The following is a description of a gene set: Human Gene Set: GOBP_REGULATION_OF_CATABOLIC_PROCESS studied in species Homo sapiens Any process that modulates the frequency, rate, or extent of the chemical reactions and pathways resulting in the breakdown of substances., and this is the list of marker genes: STYX, ABCA2, USP7, ERCC4, ATP6V0D2 (ATPase H+ transporting V0 subunit d2), TAF9, WDR45, IDH1, ATXN3, MIR9-1, SIRT2, EP300 (E1A binding protein p300), CDK5R1, SLC11A1, RAD23B, APOC1, BTG2, LRIG2, TIRAP, SYNCRIP, RIPK2, PAFAH1B2, NRBP2, CIRBP, PLK2, LZTS1, HTRA2, TRIM32, CASC3, TOB1, WNK1, XIST, RPL11, CSNK2B, ARNT, VCP, MEX3D (mex-3 RNA binding family member D), PHAX, TAF1, MIR181B1, TMEM39A, TRIM67, ASB9, MIR365A, DELE1, GBA1, SCFD1, MALAT1, PIK3CB, SH3RF3, ATP6V1C2, MIR100, DXO, ATP6V0A1, HIPK2 (homeodomain interacting protein kinase 2), MAD2L2, UBE2A, MIR373, DRAM1, CREBRF, DNM3OS, DFFB, NRDE2, IFNB1, MIR140, MIR625 (microRNA 625), ATP6V0A2, CACNG7, IER3, MIR655, CDC37, SMARCC1, IRS1 (insulin receptor substrate 1), UCHL5, MTCH2, TNF, TRDMT1 (tRNA aspartic acid methyltransferase 1), AKT2, CARHSP1, RHBDD3 (rhomboid domain containing 3), USP13, GCK, CAPRIN1, FASTKD1, IL10, EIF6, TNRC6A, USP38, PPP2CA, FOXO3 (forkhead box O3), MIR20A, PDE12, PIP4K2B, TRIM27, ADAM9, MIR145, ROCK2, TIMP4, ADRA1A, SESN3, PPTC7, BCL2L1, KCNE2, DHRSX, CDC20, FBXL5, TFEB, MIRLET7C, DISC1, POLR2G, MIR200C, ZFP36L2, MIR27A, METTL1, CCNY, CUL4B, FASTKD3, MIR106B, APOC2, MIR137, ZFP36L1 (NCBI Gene Id 677), CDH1, NPC1 (NPC intracellular cholesterol transporter 1), UVRAG, TECPR1, RNH1, DAB2IP, KEAP1, SNX7, VPS26B, MDM2, RRAGD, MIR199A1, SCARB2, CLSTN3, CSNK2A1, LRPPRC, ENDOG, LAPTM5, PRKAG2, MAPK8, FBXL4, SF3B3 (NCBI Gene Id 9661), PFKFB1, RPL23, LSM1, USP33, INS, CISD2, SRSF1, MIR30B, RBX1, ACACB, NEAT1, TPCN1, ZMPSTE24, FOXK2, BSCL2, CDC20B, DHX9, LARP4B, MIR98, ATP6V1A, ATXN3L, SOX17, EGF, STK38L, SCT, PRXL2C, PML, ACER2, APOA2, LAPTM4B, MET, UBE3A, METTL16, RAB26, SH3GLB1, PKD1, PABIR1, SH3RF1, PRKCE, HERPUD1, ATG12, CAMKK2, UBB, RBM10, MTM1, NPRL2, SCOC, N4BP1, ENPP7, SEC22B, EGLN1 (NCBI Gene Id 54703), UBQLN2, PATL1, HDAC4, PIK3CG, HPGD, PPP1R3B, GPD1, PSME3, CNOT3, OGT, NLRP6, AGTPBP1, ATP6V1H, CNOT2, MFSD2A, OAZ1, DFFA, DAZ2, VPS29, TRIB2, KAT2B, ODC1, ABHD5 (abhydrolase domain containing 5, lysophosphatidic acid acyltransferase), MIR608, GAPDH, TIMP3, MIR96, HNRNPA0, IFNG, SH3D19, RUFY4, ELOB, SMAD3, PSMD3, SIRT1, MIR29B1, RBM33 (RNA binding motif protein 33), ARID5A, MIR125A, MAP1A, PIK3R2, MUL1, DDIT4, FUT1, MIR519D, DCAF12, HDAC6, TMEM9, TTC5, GRIN2A, MIR191, TRIM39, HMOX1, ELAVL1, USP9X, AZIN1, P2RX7, EIF4A3, CNOT4, GRIN2C, USP20, NKD2, VPS13D, TSPAN5, CAMLG, DDX49, PPP1R3D, LARP1, RNF180, HSPB1, BMF, PHKA1, FXR1, SMCR8, MIR564, PTPN1 (protein tyrosine phosphatase non-receptor type 1), PAN3 (NCBI Gene Id 376186), APP, MEFV, TRAF3IP2, MIRLET7B, MTOR, GDNF, ALDOB, PLEKHN1, PTK2B, MLH1, MYCBP2, MIR130A, PSEN1, UBQLN1, CDK2, MIR326, MIR517A, MIR18A, HCAR1, HIF1A, CNOT8, PDCL3, FZR1, PIK3C3, LRRK2, RBM38, CPT1A, WIPI1, RNF5, ZAR1, PHF23, PRKCD, HSPBP1, GNAI3, MFSD8 (major facilitator superfamily domain containing 8), MIR211, HSP90AB1, MIR34B, CSNK2A3, MIR423, PKP3, PATL2, RNASEL, SNX18, MYD88, A1CF, ATRAID, ATP6V1E1, MIR21, BAG5, EEF1A2, CSNK2A2, DCN, TRAF5, FOXF2 (forkhead box F2), GPX1, PSMD2, CSDC2, APOA5, TAB2, SNF8, RNF139, IDE, NBAS, TRIM65, ZCCHC17, ABCD2 (ATP binding cassette subfamily D member 2), CHEK2, ULK3, GSK3A, HERC1, ADORA1, CSNK1D (casein kinase 1 delta), IKBKG, PDE3B, HSP90AA1, PSME1, SERPINB12, ATP6V1B1, FBLL1, MIR210, TP53, TENT4B, TARDBP, METTL14, TIMP1, PRMT6, DAPL1, MIR342, LEP, TP53INP1, MIR103B1, TPCN2, TRIM71, MIR19B1, AXIN1, PLK3, MIR491, GIT1, CDK5, USP30 (ubiquitin specific peptidase 30), PHKG2, PARL, LRP1, MIR206, RC3H2, PSMC4, IGF2BP3, GPR137B, DHX36, ZC3HAV1, IRAK3, TICAM1, SLC2A6, EGFR (epidermal growth factor receptor), VHL, C9orf72, MCL1, EXOC4, SLC7A5, CAPN1, VIM, MT3, MIR495, ELAVL4, EIF4G2, ALK, F8A3, QRICH2, PYHIN1, FYN, CRYBA1, TENT5D, WASHC1, DTL, FLNA, MIR26B, MIR142, VIP, MSN, LRP2, SETD2, TNKS1BP1, FYCO1, LACRT, ANGEL2, RELA, HNRNPC, AADAC, UBE2K, YBX3, RCHY1, ZFAND2A, PAQR3, RMC1, PABPN1L, KHSRP, DACT1, ATG101, MIR203A, MIRLET7A1, KAT5, PIK3CA, DDA1, L3MBTL3, GPR137, PITHD1, PACSIN3, ATP6V0E1, MIR4286, NUB1, NEURL3, TSPAN17, DAB2, MIR320A, XPO1, IL33, GFAP, MIR190B, ZER1, APC, MARCHF2, HSF1, BBS7, DEPDC5, TMX1, SOCS5, DRAM2, LATS1, PSMD10, PIP4K2C, TRIM40, YTHDF1 (YTH N6-methyladenosine RNA binding protein F1), CHFR, CST3, RAB37, AGO3, RAB3GAP2, PNPLA2, CPEB3, AGBL4, TSC1, RAD23A, TGFB1I1, ZYG11B, UBXN1, KDM4A, ARL2, TNFSF12, EHMT2, HTR2A, WNT5A, STING1, HOTTIP, CLEC16A, MIR199B, PIK3R4, SHH, ASB5, MIR27B, MAPKAPK2, MIR20B, METTL3, FASTK, F8A1, PIAS4, TENT4A, CISD1, PLK1, MIR23A, HNRNPD, AQP11, TLK2, MIR93, AGO4, CAV3, STX5, APAF1, BCL2, ZDHHC19, RHEB, ITCH, ADRA2A, PSMC3, MIR562, EIF4G1, EGLN2 (NCBI Gene Id 54750), PTPN3, EEF1A1, RPTOR, PANO1, NDUFA13, NANOS2, XBP1, PIK3C2A, BNIP3L, SREBF2, TLR9, ZC3H18, USP36, FBXO2 (NCBI Gene Id 4930), DAPK3, TRIM8, RNFT2 (NCBI Gene Id 84900), SLIRP, NSF, GIGYF2, FHIT, NOCT, WDR6, RNF152, MAD2L1 (mitotic arrest deficient 2 like 1), MIR195, SNX12, DCAF1, PRKAA1, MAGEA3, CNOT6, TIGAR, AMBRA1, RNF185, WDR91 (NCBI Gene Id 29062), TREX1, DAZL, IRGM, E2F1, FKBP8 (NCBI Gene Id 23770), GAPDHS, IL4, VPS13C, INSR, PTK2, TMEM168, EZR, PHB1, PPP2R3A, RAB8A, MIR497, SOCS4, GPC3, GPLD1, NICOL1, PCSK9, NANOS1, CNOT6L, SCGB1A1, ZC3H12A, PHF20L1, BCAP31, EIF2AK1, PRR5L, ZBTB7A, ATP6V1B2, ANGPTL3, SGTA, CYP51A1 (NCBI Gene Id 1595), DEPTOR, TRIM21, MIR337, PIN1, HNRNPAB, DET1, RAB7A, RIDA, TUT4, SNX3, MIR544A, SAMD4A, COP1, HNRNPU, BTRC, IRGQ, PCBP4, PABPC1, PAIP1, USP5 (ubiquitin specific peptidase 5), SMAD7, SMAD4, ABCB11, TMTC3, SAMD4B, LRSAM1, EPM2A, TBRG4, NT5C3B, WDR41, TF (transferrin), ATP6V1C1, GGA3, DAP, CNOT11, CEBPA, FURIN, USP19, EXOC8, HUWE1, DCP1B, HSPB8, MIR181D, DTX3L, TENT2, MAPT, CSNK1E, PIM2, MIR19A, MIR517C, RPS7, ABL1, DAOA, NOD1, CAPNS1, TMEM59, MGAT3, PIWIL2, MIR665, NUDT15, ZC3H12D, RBM46, SPTLC2, MIR302C, DNM1L, CSDE1, SPTLC1, TRIB3, VSIR, TENT5B, FAF1, SLC4A1, SUFU (SUFU negative regulator of hedgehog signaling), DDIT3, UBXN2A, ELAPOR1, MAP2K1, ULK2, CBLB, IGF2BP2, DAPK2, HAX1, MTMR2, MIR212, YTHDF2, CDK16, PKP1, VPS35, GATA5, CUL3, TUT7, ANXA2, GTSF1, NOP53, FUS, RBM8A, FOXO1 (forkhead box O1), ZKSCAN3, MIR663A, HGF, DAGLB, MIR329-1, DIS3, EIF3H, YTHDF3, MIR128-1, DESI1, FXR2, MYLIP, GIPC1, UBQLN4, ARAF, KAT8, TRIM13, NCOR1, CNOT7, ATG5, RIC1, BAG6, SERPINE2, EIF4ENIF1, SERBP1, SUMO2, ATP6V0B, MAGEA6, NOD2, MIR520C, PRKAA2, MAGOH, RARRES2, FEZ1, PAN2, CELF1, PLIN5, APOE, CHMP6, ZNF418, RHBDD1, VPS26A, MIR483, YBX1, ATP6V1G1, NQO1, MIR302A, MIR106A, SNX33, FTO, MIR223, ARHGAP5-AS1, ATP6V1G2, FBXL2, ATP6V0C (ATPase H+ transporting V0 subunit c), NPRL3, DAZ1, PPARA, MIR135B, EIF4E, FAM76B, MIR149, UPF3A, PRKACA, ATG16L1, PSAP, OAZ3, LEPR, CALCOCO2, TSC2, TOM1, BARD1, HMGB1, VPS28, ABL2, IGF1, PNPT1, USP8, IRS2, ACTN3, DIS3L2, UPF1, MIR204, RILP, OSBPL7 (NCBI Gene Id 54871), AXIN2, UFL1, MOAP1, MTCL2, UCHL1, SH3BP4, MAP3K7, MAPK9, SREBF1, PSMC2, GABARAP, FOXK1, ROCK1, MIR214, MIR200B (NCBI Gene Id 406984), CNOT9, NPM1, FMR1, MIR181A2, APEX1, RPGR, PRKAG1 (protein kinase AMP-activated non-catalytic subunit gamma 1), DCP2 (decapping mRNA 2), SNX32, PABPC4, TIPARP, TWIST1, RNF41, MIR185, CCDC22, MIR708, FBXW7, SESN1, MIR181C, ATP6V0E2, ZBTB20, NSUN2, HAMP, DEPP1, PRICKLE1, FAP, MAPK14, ADCY10, ZNF268, CASP3, HFE, PSMF1, MIR192, SNX4, TOMM7, USP14, IREB2 (iron responsive element binding protein 2), BECN1, RRAGC, TRAF2, MAGOHB, TREM2, GCLC, STUB1, PSME3IP1, HSPA1B, FLCN, SUPV3L1, TRIB1, DNAJB2, PARN, USP26, SNCA, PSMD14, MDM4 (NCBI Gene Id 4194), DVL1, EIF4G3, PTPN22, UBQLN3, TIMP2, TBC1D25, ADAM8, FBP1, AGO2, ASB11, FAM83D, RGMA, CDK5RAP3, HK2, IL10RA, PLEKHF1, PRKN (NCBI Gene Id 8004), NEDD4, SLC35D3, VPS11, RFPL1, DDRGK1, NAT8B, TYSND1, KLHL22, APOA4, PPP1CA, CTSA, NFE2L2, RAB3GAP1, MIR486-1, CAV1, MTLN, ITPR1, TAF15, RNF31, SCARB1 (scavenger receptor class B member 1), STK11, MIR151A, RUBCN, TMEM132A, MID2, DCPS, RB1CC1, WNT1, BAG2, ATP6V0D1, PRKCA, CENATAC, LYPLA1, NOS2, RYBP, MIR1-1, CIDEC (NCBI Gene Id 63924), FBXO7, RNFT1, SNX1, MIR501, VGLL4, SRC, ATG14, MIR424, RASIP1, DHX34, ERFE, AMER1, MEIOC, PRKCG, CDKN1B, GABARAPL2, TAB3, MIR130B, BOK, FMC1 (formation of mitochondrial complex V assembly factor 1 homolog), IL1B, ORMDL3, FZD5, FASTKD2, NANOS3, EXOC1 (NCBI Gene Id 55763), PSMC5, BAD, ATP6V1D, FBXL20, IGF2BP1, ATG2A, GOLGA2, PUM1, ATF6, ADRB2, CLN3, SGSM3, MAPK15, NKD1, IFI16, GPSM1, MLXIPL, DEDD, RGP1, SUPT5H, SMURF1, NRDC, NMNAT1, FEZ2, TRIM63, CDKN2A, RALB, ADGRB1, MAPK3, SENP1, PINK1, UBR4, MIR133A1, CLU, NUPR1, PIP4K2A, STAT3, THRA, JMJD8, GATA4, MIR519A1, ZC3H14, MIR885, DAPK1, CD81 (NCBI Gene Id 975), TTC36, SNX6, MIR146A, CRTC3, WAC, TRIM23, NAF1, PUM2, AGAP2, VDAC1, MIR24-1, OPTN, PSMC1, CPTP, FASTKD5, MTDH, TNRC6C, SNX5, F8A2, BAG3, WDR24, HP, SQSTM1, ECSCR, TRAF7, CIDEA, SECISBP2, C4BPA, ZDHHC2 (NCBI Gene Id 51201), GSK3B, ALAD, LONP2, ETFBKMT (NCBI Gene Id 254013), MIR340, FBXW8, CALCR, TSPAN15, PSMC6, MARCHF7, NEDD4L, XPA, RRAGB, MTCL3, ZSWIM8, DKC1, CCAR2, HGS, DNAAF4, PNLDC1, GRSF1, ATG7, RRAGA, AURKA, NELL1, HMGCR, DDB1, PBK, ATM, ULK1, MOV10, DND1, DCP1A, TENT5A, CSNK1A1, CERS1, APOBEC1, TMEM259, ATP13A2, OAZ2 (NCBI Gene Id 4947), PSMD1, TRIM22, OPHN1, COMMD1, RBM24, SESN2, SOX9, MIR543, DAZ3, POLDIP2, AKT1, UBR3, TBK1, GGA1, GLMN, SNX30, THRAP3, FBXO22, CNOT10, WNT10B, MTCL1, HSPA1A, CTTN, RC3H1, TSPO, NNT, ATG13, GTPBP1, NDFIP1, KIF25, SH3RF2, CBFA2T3, RACK1, TNFAIP3, ENDOU, LIN28B, PSME2 (NCBI Gene Id 5721), LDLR, ITGB1, RNF128, ERN1, BNIP3, HTT, MIR485, BOLL, RDX, ATP5IF1, TBC1D14, CNOT1, IKBKE, USP10, SLC25A4, MTMR9, KLHL40, PRKAG3, TMF1, SIRT6, QSOX1, MIR16-1, SORL1, C4BPB, ATP6V1E2, LPCAT1, HECTD1 (HECT domain E3 ubiquitin protein ligase 1), TENT5C, QKI, ZDHHC7, PTEN, MIR127, PRKD1, ATP2B4, SLC25A5, MIR193A, PIWIL1, GNA12, RBM47, HCAR2, ZFP36, PYCARD, IL6, PIAS1, RHBDF1, EXOC7, NORAD, MLYCD, SLC4A4 (solute carrier family 4 member 4), ABCD1, APOC3, LAMP3, PARK7, CUL4A, KDR, BAX (NCBI Gene Id 581), RAB39B, FMN2, AGO1, TNRC6B, WFS1, MIR125B1, SNX9 (sorting nexin 9), ALKBH5, LARP1B, MTMR8, RPL5, DAZ4, SNRNP70, USP25, SVIP, MIRLET7E, TNFRSF1B, MLST8, NFE2L1, SUMO1, AZIN2